Given this list of marker genes NGF, CLTA, AP2S1, DNM2, AP2A2, DNAL4, CLTC, SH3GL2 (SH3 domain containing GRB2 like 2, endophilin A1), DNM1, AP2B1, AP2A1, NTRK1, AP2M1, DNM3, here is a description of the gene set: studied in species Homo sapiens Reactome Pathway: Retrograde neurotrophin signalling part of: Signaling by NTRK1 (TRKA) Neurotrophin-TRK complexes can be internalized and enter signalling vesicles, which travel retrogradely over long distances from distal nerve terminals to neuronal cell bodies. Such retrograde signalling by neurotrophin-TRK complexes regulates survival, synaptogenesis and maintenance of proper neural connectivity. The neurotrophin-TRK complex may use three distinct internalization pathways. Although Clathrin-mediated endocytosys appears to be the major internalization route, it is controversial whether it also represents the dominant pathway for retrograde transport and signalling. Pyncher-mediated endocytosis might be more relevant in this regard. Moreover, also caveolin-mediated endocytosis may play a role in NGF-TrkA internalization.<br>Retrograde transport of TRKs is microtubule-dependent: TRKs remain activated and bound to neurotrophins during retrograde transport. The current view is reflected in the signalling endosome model. It is a specialized vesicle containing ligand (NGF, BDNF) bound to its activated TRK receptor, together with activated downstream signalling proteins, transported by motor proteins (dyneins) from nerve terminals to remote cell bodies, where the receptors trigger signalling cascades.